Given this list of marker genes Eno1, Pid1, Eno1b, Antkmt, Ndufc2, Slc25a12, Ppara, Rd3, Vcp, Guca1a, Atp5if1, Hnf1a, Il4, Bcl2l1, Adcy10, Adora2b, Atpsckmt, Tmsb4x, Map2k1, Parp1 (poly (ADP-ribose) polymerase family, member 1), Guca1b (guanylate cyclase activator 1B), Stat3, Nos3, Dnajc30, Sphk2, Myc, Prkn, Trem2, Entpd1, here is a description of the gene set: species: Mus musculus Mouse Gene Set: GOBP_REGULATION_OF_NUCLEOTIDE_BIOSYNTHETIC_PROCESS Any process that modulates the frequency, rate or extent of the chemical reactions and pathways resulting in the formation of nucleotides.